The following is a description of a gene set: Mouse Gene Set: GOBP_LYMPHOCYTE_ACTIVATION_INVOLVED_IN_IMMUNE_RESPONSE species: Mus musculus A change in morphology and behavior of a lymphocyte resulting from exposure to a specific antigen, mitogen, cytokine, chemokine, cellular ligand, or soluble factor, leading to the initiation or perpetuation of an immune response., and this is the list of marker genes: Kctd9, Mtor, Stat4, Rif1, Havcr2, Zfp683 (NCBI Gene Id 100503878), 6030468B19Rik, Plcg2, Prkcz, Shb, Smad7, Nlrp3, Tbk1, Gm13277, Ung, Mir181b-2, Trp53bp1, Ddrgk1, Ptger4, Phf14, Dock10, Socs5, Pf4, Psen1, Xrcc4 (NCBI Gene Id 71945), Cdh17, Ifna11, Kmt2a, Rara, Gm13271, Zc3h12a, Pms2, Hspd1, Lgals1 (NCBI Gene Id 16852), Ifng, Pglyrp2, Muc19, Cd69, Mir181b-1, Irf8, Nfkbiz, Hlx, Ceacam1, Gm13275, Aplf, Foxp1, Il4ra, Cd81, Ifnab, Rc3h2, Rnf8, Eif2ak4, Mdk, Rab27a, Pglyrp1, Ifna15, Il27, Plxna1, Mir873a, Mfng, Relb, Irf4, Pou2af1, Msh2, Swap70, Nckap1l, Il18 (NCBI Gene Id 16173), Trp53, Atad5, Mir326, Lgals8, Pcyt1a, Apbb1ip, Icosl, Nkg7, Il27ra, Sema4a, Stat6, Coro1a, Malt1, Brd4, Ifna4, Jak3, Ccr6, Icam1, Xbp1, Ifna7, Rnf168, Cd40, Gata3, Lig4, Shld2, Cd19, Ifna5, Ifnk, Tnfsf13, H2-DMb1, Men1, Pglyrp4, Shld3, Hmces, Ptprc, Tnfaip3, Slc11a1, Mir301, Gm13276, Stx11, Ada (NCBI Gene Id 11486), Ccr2, Ifne, Ascl2, Parp3 (poly (ADP-ribose) polymerase family, member 3), Il21, Tbx21 (NCBI Gene Id 57765), Cracr2a, Cd180, Slamf6, Mad2l2, Ripk2, Sema6d, Rora, Ifna6, Clcf1, Pagr1a, H2-M3, Cd28, Ifna13, Fcer1g, Ndfip1, Itfg2, Rps6, Kmt5b, H2-DMb2, Stat3, Cd74, Exosc6, Pglyrp3, Itgb6, Dll1, Dock11, Supt6, Rc3h1, Slc15a4, Entpd7, Il6ra, Pik3r1, Lilrb4a, Otud5, Sanbr, BC037156, Gpr183, Abl1, Tnfsf4, Ap1g1, Shld1, Tlr4, Spn (NCBI Gene Id 20737), Exo1, Ifna1, Ifna12, Tsc1, Fcgr4, Itgb8, Fgl2, Clec4e, Slfn2, Ifnb1, F2rl1, Lgals3, Nkx2-3, Enpp1, Nsd2, Kmt5c, Atp7a (ATPase, copper transporting, alpha polypeptide), Zfp35, Ly9, Plcl2, Opa1, Ifna14, Ptk2b, Itgal (integrin alpha L), Ercc1, Il10, Bcl6, Batf, Eomes, Msh6, Lef1, Lgals9 (NCBI Gene Id 16859), Mlh1, Cd46, Tfrc, Unc13d, Psen2, Gm13283, Rag2, Il4, Ep300, Ifna9, Nbn, Brd2, Aicda, Zbtb7b, Cd244a, Anxa1, Lamp1, Gapt, Notch2 (NCBI Gene Id 99749), Nfkbid, Paxip1, Il18r1, Ccl20, Ifna16, Irf1, Ifna2, Rorc, Il6, Tmem98, Il2, Loxl3, Gadd45g, Itm2a, Ccr7, Tnfsf18, Tgfb1, Ifnz, Il23a, Gm13272, Il12b, Myb, Cd160, Ccl19, Lfng (NCBI Gene Id 16848), H2-Ea, Lcp1, St3gal1, Exosc3, Cd40lg, Clec4d, Foxp3, Pck1, Hmgb1, Bcl3, Spi1, Trem2 (NCBI Gene Id 83433), Tyrobp